The following is a description of a gene set: species: Homo sapiens To identify signature genes that help distinguish (1) sepsis from non-infectious causes of systemic inflammatory response syndrome, (2) between Gram-positive and Gram-negative sepsis. from publication Payen D, Lukaszewicz AC (PMID 19535937) Human Gene Set: GSE9960_GRAM_NEG_VS_GRAM_POS_SEPSIS_PBMC_UP Genes up-regulated in peripheral blood monocytes (PMBC): Gram negative sepsis versus Gram positive sepsis., and this is the list of marker genes: MIER1, TMEM41A, BCL3, MYPOP, VTI1A, CGAS, MYO19, TRAF1, ISG20, RAD21, PTPN12, SLC43A3, SLAMF7, PLAUR, PTGER4, PTCD1, ZNF444, PKNOX1, XAF1, INHBA, ARFRP1, TAGLN2, MLLT11, NELL1, ST3GAL2, B3GALNT1, BTG3, MIR3945HG, SERPINB5, PDCD6IP, WBP4, BATF, USP18, TNIP2, SYNE4, PIM3, HCN3, LRWD1, MMP14 (matrix metallopeptidase 14), TUBB, SLC2A6, C1orf122, ITGB8, PARP10, MARS1, IFI44, LYRM1, DTX3L, PSMA2, ALOX15B, NDEL1, IFIT3, AK4, GBP1, OSM, LINC02800, NABP1, PPP1R15B, IFITM3, EPS8L2, N4BP1, IL15RA, C20orf204, AGRN, FAM200A, EFCC1, CDKN1A, CD58 (CD58 molecule), STAT3, TRIP10, CYTIP, PIK3AP1, ATXN7L3, FADS3, PEF1, CALM1, TRIM62, DNAJC18, NDRG1, EPSTI1, CHMP5, IL10RA, TNFAIP8, RASGRP1, JAK3, EZH2, RAB8A, F3, CSF2RB, EDEM1, DUSP4 (NCBI Gene Id 1846), IRAK2, GK3, PER1, ETV3, TICAM1, NET1, GPAT4, KIAA1191, STAT1, ALKBH6, GK, IFITM2, CUL1 (cullin 1), PITPNA, ADA (adenosine deaminase), MMP7, COQ10B, TAPBP, NDE1 (nudE neurodevelopment protein 1), HELZ2, FTH1, LINC01465, BMAL2, IGSF8, TSPAN3, P4HA1, LRRC32, SEMA6C, TNFRSF9, ZNRF2, FPGS (folylpolyglutamate synthase), RAPGEF2, GRAMD1A, ADGRE1, NFE2L1, ENPEP, TSPAN33, PABIR2, ADPGK, KRT33A, SAMD9L, NDP, DESI1, CLEC4D, DNAH10, PDSS1, ANKRD33B, HERC5, C8orf76, CARD16, FAM223B, IFI44L, PSMA5, RGS1, TRIB1, MCM5, GP1BA, HES4, BST2, HCK (NCBI Gene Id 3055), COPS2, ENSG00000284634, PLEKHM3, HDGF, CFLAR, BEST2, PSMC6 (proteasome 26S subunit, ATPase 6), IRF7, NUDCD1, LINC01720, ZNF697, CERS5, DNAI3, UBE2NL, PSMA3, PSME1, ICAM1, NMI, CARD19, UGP2, MYLK, RGS7, SLC39A1, IGHG1, TMOD1, TNFSF9, NMT1, GCH1, FOSL1, PPP1R18, UBE2S, TMEM39A, ARHGAP28, SCAMP3, ASIC4, DDA1 (DET1 and DDB1 associated 1), CXCR6, GPR162, SNX10, AS3MT, LINC01341, TMEFF1, TNFRSF4, BTG1, ELOVL1, CHST2